The following is a description of a gene set: from publication Kaji T, Ishige A, Hikida M, Taka J, Hijikata A, Kubo M, Nagashima T, Takahashi Y, Kurosaki T, Okada M, Ohara O, Rajewsky K, Takemori T (PMID 23027924) Genes up-regulated in follicular B cells versus day 7 germinal center B cells. Human Gene Set: GSE11961_FOLLICULAR_BCELL_VS_GERMINAL_CENTER_BCELL_DAY7_UP species: Homo sapiens To obtain insight into the genetic basis of the increase of functional activity of memory B cells over time, we compared the gene expression profiles of day 7 and day 40 NP-specific/IgG1 memory B cells, GC B cells and plasma cells in immunized WT mice and naïve B cells, before and after activation in vitro., and this is the list of marker genes: EIF2AK4, PRKAR2B, HGSNAT, PIP4P2, CHM, CXXC5, ACOT13, AKTIP, SLC7A6, ORMDL1, SPRTN, MTA3, PCDHB4, LRRC40, ST3GAL4, SSTR3, DHX40, CCPG1, PADI2, GIN1, TTL, TNFAIP8, BMS1, RRH, SMPD1, WDR44, CEP70, MTARC2, PWP1, PDP1, MKRN3, CDYL2, TXNL4B, TWNK, HS2ST1, ATP23, PPA2, NEDD4, TSPYL4, DEPTOR, SLC25A32, GAL3ST1, PDE1C, C2CD3 (C2 domain containing 3 centriole elongation regulator), EIF1B, ZNF597, TMED7, GZF1, ZDHHC20, METTL8, AGO4, KLHDC2, PI4KB, OGFOD1, SNAPC5, WIPI2, PAQR7, CELF4, RNF220, DKK3, PINK1, MMGT1, HOXD4, EHBP1, PLA2G4A, TMEM161B, HARBI1, PRPH, HHAT, GPR179, CD34, ZNF638, SCML4, ACSL3, FERMT3, AJUBA, LPAR6 (lysophosphatidic acid receptor 6), CYP2B6, VRK2, MICU3, FRMPD1, OXR1, GNL2, EIF4E3, PRKCI, HNRNPR, BTG3, MCF2 (NCBI Gene Id 4168), NTPCR, FAM3C, KLHL42 (kelch like family member 42), BBS10, MMUT, XPR1, SQOR, MYO1H, RWDD2A, CNOT2, CERS5, SC5D, BEST1, LMO7 (NCBI Gene Id 4008), SQLE, POLE3, WDR11, CD44, TRMT11, PON2 (NCBI Gene Id 5445), FOXO3, MLH1, ZNF157, NCAPG, INO80C, PDK1, DPM2, NOL7, TIMM8A, SESN3, LAIR1, FAM78A, CIITA, ERCC4, LRRIQ3, NHERF2, GEMIN4, GDI2, DPP4, PALS1, VMAC, PAXX, TBC1D31, FRA10AC1, RPS6KA2, PPCDC, MRPS35, DAB2, TOP3B, MTUS1, SMPD2, FAM120A, TMCO6, RDH10, ABHD12, MTHFD1L, ARL15, ARHGEF4, SPATS2L, ADAM10, SLC29A2, FAM32A, FUT11, TBC1D24, HOXA7, CAST (NCBI Gene Id 831), NOCT, FZD7, MCTP1 (multiple C2 and transmembrane domain containing 1), EIF2AK3, KIFAP3, CRYAB, BCOR, PHYHIP, TM7SF3, TFAM, EXOC7, BLOC1S5, TCEAL1, PRXL2C, NRP1, FHIP2B, PABPC1, FOXO1, ARHGAP9, DDX28, GPN3, MBD6, ASPSCR1, POLR3G, MEF2D, PRUNE1, TRIM23, EXOSC1 (exosome component 1), LARS2, SPAG16, NCKAP1L, SNRK, LRRC56, TSPAN2, CFAP298, PPP2R5E, RAB3GAP1, GSN, APPL1, HMGCR, RPS6KA5, RDH14, PEX11B, VSTM2A, PHTF2, SENP8